Given this list of marker genes EPB41L2, GNAI1, CACNG2, VPS26B, CSK, EPM2A, CNPY4, AGR2, ITGB1 (NCBI Gene Id 3688), PLS1, LGALS3, EPB41L3, ACTB, TRAF6, LYPLA1, TREM2, LDLRAP1, PRNP, CAMK2D, STAC2, ADAM10, GPSM2, DLG1, CAMK2A, NUMA1, PICALM, ATP2B4, ZDHHC5, EPHA3, WNK1, IQSEC2, SAPCD2, CAMK2G, DAB2, ABI3, EPHA2, ACSL3, STAC, NUMB, WNK3, RAB11FIP2, GPC4, GPC6, RAP1A, GPER1, WNT3A, EPHB2, PKDCC, MMP14, PIK3R2 (NCBI Gene Id 5296), CSRP3, ARHGAP44, AP2M1, EPB41, RAB38 (NCBI Gene Id 23682), VPS35, CDK5, STAC3, LYPD1, RAMP3, EGFR, VTI1B, MRAP2, PPFIA1, PLK1, OLFM1, MAP2K1, RSC1A1, COMMD1, CLIP3, GRIPAP1, TMBIM1, TMEM59, GBP1, WNK4, RANGRF, ANXA13, SORBS1, ARHGEF16, TGFB1, CAMK2B, RACK1, ZDHHC7, SPTBN1, STX7, ATP2C1, AKT1, INS, LZTFL1, STX3, CPLX1, RER1, SNCA, LRRC15, APPL1, STX8, VPS4A, MIR223, PKP1, STX4, PRKCI, GHSR, PGRMC1, VAMP8, PIAS1, KIF2C, ARF6, IFNG, EZR, RAB11A, GABARAP, AR, PIK3R1, HRAS, CIB1, TMEM108, NETO2, RHOQ, DPP10, PDPK1, CNST, LYPLAL1, NRXN1, ZDHHC2, MRAP (melanocortin 2 receptor accessory protein), LRP1, PID1, SFN, EIF4G1, PTPN9, OGT, VIL1, PRKCH, CACNA2D2, TMED2, SQSTM1, TNF, ITGA3 (NCBI Gene Id 4454), DAG1, CLN3, AKAP5, ABCA2, SIRT6, PPP1R9B, CLTC, KIF5B, VAMP4, MISP, PRKCE, BCL2L1, NHLRC1, RHOG, ZDHHC8, PPP2R5A, EFCAB7, NKD2, here is a description of the gene set: Any process that modulates the frequency, rate or extent of protein localization to cell periphery. Human Gene Set: GOBP_REGULATION_OF_PROTEIN_LOCALIZATION_TO_CELL_PERIPHERY studied in species Homo sapiens